The following is a description of a gene set: from publication Cui S, Li C, Ema M, Weinstein J, Quaggin SE (PMID 16207825) species: Mus musculus Genes most strongly down-regulated in kidney glomeruli isolated from TCF21 knockout mice. Mouse mutations have provided tremendous insights into the molecular basis of renal and glomerular development. However, genes often play important roles during multiple stages of nephrogenesis, making it difficult to determine the role of a gene in a specific cell lineage such as the podocyte. Conditional gene targeting and chimeric analysis are two possible approaches to dissect the function of genes in specific cell populations. However, these are labor-intensive and costly and require the generation, validation, and analysis of additional transgenic lines. For overcoming these shortcomings and, specifically, for studying the role of gene function in developing glomeruli, a technique to isolate and purify glomeruli from murine embryos was developed. Combined with gene expression profiling, this method was used to identify differentially expressed genes in glomeruli from Pod1 knockout (KO) mice that die in the perinatal period with multiple renal defects. Glomeruli from early developing stages (late S-shape/early capillary loop) onward can be isolated successfully from wild-type and KO kidneys at 18.5 d postcoitus, and RNA can readily be obtained and used for genome-wide microarray analysis. With this approach, genes that are differently expressed between glomeruli from Pod1 KO and wild-type mice were identified, including a four-fold reduction of alpha 8 integrin mRNA in glomeruli from Pod1 KO mice that was confirmed by immunostaining. This procedure may be adapted to any transgenic strain, providing a rapid and efficient method to dissect the function of specific genes in glomerular development. Mouse Gene Set: CUI_TCF21_TARGETS_DN, and this is the list of marker genes: Pde10a, Serpinb6b, Rhpn1, Hspa1b, Gabra4, Scd2, Slc12a2, Lrrfip1, Parp4, Tspan2, Sema3e, Adamts5, Nphs2, Mertk, H3c15, Tlr4, Egf, Ptger4, Clic5, Rassf10, Hspa1a, Fam241a, Cd55, Sh3bgrl2, Top1mt, Umod, Art3, Mapt, Iqgap2, Galc (NCBI Gene Id 78595), Sgip1, Col4a3, Ptprv, Adm